Given this list of marker genes Nedd4l, Kcnn4, P2rx7, Kcne5, Hcn4, Kcnj14, Kcnq2, Kcna5, Wnk1, Lrrc52, Sgk1, Mcoln1, Kcna1, Kcnk7, Dlg1, Kcnc2, Kcnc4, Kcnj15, Lrrc26, Kcnip1, Fxyd5, Kcnab2, Kcna6, Kcnk3, Kcnip4, Cav3, Tmem38a, Kcnk6, Wnk4, Ccdc51, Kcnk13, Kcnq1, Kcnc3, Kcnj13, Kcnt1, Kcnj12, Kcnn2, Kcnk10, Gria2, Kcna10, Kcnf1, Kcng2, Kcne3, Kcnmb4, Kcnh3, Kcnj8, Kcnk12, Kcnn1, Kcnb1, Kcnt2, Kcne4, Kcnh1, Akt1, Kcnk1, Kcnk4, Sumo1, Kcnk15, Amigo1, Scn2b, Wnk2 (NCBI Gene Id 75607), Fxyd4, Kcnj1, Akap9, Kcnh8, Kcnq4, Kcnd2, Kcnk18, Kcnk2, Ywhae, Cav1, Kcns1, Kcna7, Kcnc1, Grik5, Kcnj16, Kcns3, Kcnmb3, Kcnq3, Pias3, Ensa, Wnk3, Kcnip3, Dpp6, Kcna4, Tmem175, Sgk2, Grik4, Trpm5, Kcnh5, Sgk3, Tmem38b, Slc5a3, Kcnh2 (NCBI Gene Id 16511), Kcng4, Kcns2, Lrg1, Lrrc38, Arpp19, Aqp1 (aquaporin 1), Prkcz, Kcnv2, Dpp10, Adrb2, Kcng3, Grik1, Hcn2 (NCBI Gene Id 15166), Kcnb2, Hcn3, Kcnq5, Kcnd1, Kcnj11, Flna, Kcnj6, Kcnk9, Kcnab1 (NCBI Gene Id 16497), Ank2, Snap25, Kcnh7, Kcnu1, Kcnj5 (NCBI Gene Id 16521), Grik3, Kcnj4, Kcnh4, Lrrc55, Hcn1, Kcna3, Kcnk5, Kcnab3, Mcoln3, Kcnn3, Kcnd3, Abcc9, Pkd2l1, Kcnmb1, Kcnj9, Kcnv1, Kcnip2, Kcnj10, Cnga2, Kcne2, Kcnh6, Kcng1, Kcnj3, Kcnj2, Kcnk16 (potassium channel, subfamily K, member 16), Kcne1, Kcna2, Kcnmb2, Abcc8, Grik2, Pkd2, Kcnma1, here is a description of the gene set: species: Mus musculus Enables the energy-independent facilitated diffusion of a potassium ion through a transmembrane aqueous pore or channel. Mouse Gene Set: GOMF_POTASSIUM_CHANNEL_ACTIVITY